Given this list of marker genes Ifit1, Isg15, Oasl2, H2-T22, Irf7, Ifitm3, Slfn9, Isg20, Herc6, Bst2, Rnf213, Ube2l6, Slfn2, Ly6a, Rtp4, Parp9, here is a description of the gene set: Genes positively differentially expressed in cell type: Mast cell upon treatment with cytokine: IFN-ε in mouse lymph nodes in vivo. Mouse Gene Set: CUI_MAST_CELL_IFNE_RESPONSE_UP Cytokines mediate cell-cell communication in the immune system and represent important therapeutic targets. A myriad of studies have highlighted their central role in immune function, yet we lack a global view of the cellular responses of each immune cell type to each cytokine. To address this gap, the authors created the Immune Dictionary, a compendium of single-cell transcriptomic profiles of more than 17 immune cell types in response to each of 86 cytokines (>1,400 cytokine-cell type combinations) in mouse lymph nodes in vivo. A cytokine-centric view of the dictionary revealed that most cytokines induce highly cell-type-specific responses. For example, the inflammatory cytokine interleukin-1β induces distinct gene programmes in almost every cell type. A cell-type-centric view of the dictionary identified more than 66 cytokine-driven cellular polarization states across immune cell types, including previously uncharacterized states such as an interleukin-18-induced polyfunctional natural killer cell state. studied in species Mus musculus from publication Cui A, Huang T, Li S, Ma A, Pérez JL, Sander C, Keskin DB, Wu CJ, Fraenkel E, Hacohen N (PMID 38057668)